The following is a description of a gene set: studied in species Homo sapiens Human Gene Set: HP_ATROPHY_DEGENERATION_INVOLVING_THE_CAUDATE_NUCLEUS Atrophy/Degeneration involving the caudate nucleus, and this is the list of marker genes: JPH3, BSCL2, ADAR, SLC2A3, TREM2, NUP62, TYROBP, TIMM8A, FTL, MT-ATP6, NEK1, LONP1, NDUFAF5, NUP54, FOXP2, ASNS, OPHN1, VPS13A, HTT